Given this list of marker genes Dnajb11, Spag7, Trappc6a, Anxa7, Rpl8, Fnta, Sarnp, Snrpb2, Rbis, Cmas, Eci2, Pdcd5, Ssb, Ybx3, Ppp1r2, C1d, Lsm6 (NCBI Gene Id 78651), Psmb2, H2ax, Slc35b1, Rps21, Ncl, Rpl4, Polr1d, Sypl1, Arpc1a, Aprt, Nucb1, Ywhae, U2surp, Magt1, Calr, Fkbp2, Mrps26, Atp6v0d1, Eif3a, Naa50, Snrnp27, Ndufaf8, Rpn2, Rbm8a, Ndufs7, Pcna, Eif6, Dpy30, Spcs1, Ube2a, Stmp1, Dek, Cyb5a, Pih1d1, Akap9, Def6, Cisd1, Cnbp, Fh1, Cyc1, Eif3i, Cited2, Cdk12, Taf1d, Atp5mf, Mtch1, Frg1, Psenen, Pycard, Dazap1, Luc7l2, Asnsd1, Mtch2, Ptpa, Rps17, Me2, Rpl19, Slc25a4, Rnaseh2c, Tmed10, Sdha, Sf3b4, Ddost, Ywhaq, Polr2j, Snx5, Psmc5, Copb2, Srsf7, Psma3, Snrpa1, Ssr2, Rpl13a, Bin1, Tprg1l, Hmgn1, P4hb, Psmc2, Arl6ip4, Magoh, Ssrp1, Anapc5, Tsen34, Ppp1r11, Eny2, Rnf187, Atp5po, Sod1, Ndufb7, Cmtm7, Iqgap2, Chchd2, Gng12, Banf1, Cct3, Ndufb8, Tpi1 (NCBI Gene Id 21991), Ilf2, Phpt1, Mrpl28, Rps3a1, Hspe1, Ube2k, Rpsa, Hnrnpk, Cox7b, Ndufa13 (NADH:ubiquinone oxidoreductase subunit A13), Ndufs4, Eef1g, Eif4a3, Stk16, Sri, Ctsd, Rab4b, Atp5mj, Psmd14, Smdt1, Unc50, Polr2i, Atp6v1d (ATPase, H+ transporting, lysosomal V1 subunit D), Smc1a, Vdac2, Snf8, Hnrnpa3, Dynlrb1, Fubp1, Mrps24, Snhg8, Sin3b, Pin1, Ppm1m, Snx1, Pgk1, Esyt1, Gas5, Tmco1, Ifitm1, Dcun1d5, Snrpg, Med30 (NCBI Gene Id 70303, mediator complex subunit 30), Ndufv2, G3bp1, Srp19, Mrps12, Idh2, Hint1, Smc6, Mien1, Ilk, B230219D22Rik, Tmem167, Arpc5l, Gng2, Chtop, Ptbp1, Psmc3, Hsp90ab1, S100a10, Rtraf, Mrpl30 (mitochondrial ribosomal protein L30), Immt, Etfb, Supt4a, Ciao2b, U2af1, Rps18, Pcnp, Polr2c (NCBI Gene Id 20021), Twf2, Dohh, Rps8, Etf1 (NCBI Gene Id 52117), Jtb, Uqcrc2, Psmd6, Pdcd10, Hnrnpdl, Psmb3 (proteasome (prosome, macropain) subunit, beta type 3), Kcnq1ot1, Prdx6, Ahsa1, Sfr1, Tmem254, Slc3a2, Slbp, Rps26, Lta4h, Rbbp4, Ufc1, Rdx, Cct4, Pole4, Sar1b, Dnaja2, Ak2, Tmem165, Antkmt, Rab24, Lrrc59, Hp1bp3, Mrpl58, Edem2, Trappc2l, Cnih4, Psme1, Lat2, Anxa1, Khk, Erp44, Sod2, Fam133b, Mrps25, Smc4, Psma1, Rtcb, Sec13, Btf3l4, Nudcd3, Cox5b, Hspd1, Idh3g, Cks2, Ankrd13a (ankyrin repeat domain 13a), Ube3a, Cox8a, Atp5me, Mrpl52, Lage3, Nsmce1, Rpl7l1, Dctn3, Emc10, Csnk1a1, Cirbp, Rer1, Ogfrl1, Sumo1, Luc7l3, Mvb12a, Glipr1, Naa20, Psmb4, Rbm17, Nudt21 (nudix hydrolase 21), Psmb5, Vrk1, Tmem256, Ola1, Jchain, Thoc7, Rplp0, Glrx5, Swi5 (NCBI Gene Id 98849), Vmp1, Atp5f1b, Mif, Trappc6b, Naca, Cdc26, Ube2n, Pin4, Cuedc2, Rpl15, Chchd3, Dnajb6, Psma7, Cenpx, Ndufs2, Rpl7a, Cdc5l, Vdac3, Sdhc, Ebp, Dnajc19, Rpl36al, Hnrnpd, Ewsr1, Impdh2 (inosine monophosphate dehydrogenase 2), Rps25, Commd2, Ndufa12, Nars1 (asparaginyl-tRNA synthetase 1), Mdh2, Gm9320, Sdf4, Cisd2, Fundc2 (NCBI Gene Id 67391), Prdx3, Canx, Uba2, Eif3g, Osgep, Bin3 (NCBI Gene Id 80552), Park7, Srsf2, Nans, U2af2, Mlf2, Stmn1, Vars1, Ndufc2, Bcas2, Reep5, Anapc13, Taf10, Cox7a2, Commd7, Eif1ax (eukaryotic translation initiation factor 1A, X-linked), Sdf2l1, Lamtor5, Snu13, Pebp1, Casp8, Acadl, Cdk4, Atp5mc1, Hmg20b, AW112010, Cd47, Phb1 (NCBI Gene Id 18673), Rps6, Emg1, Rps20, Mrpl4, Cct8, Cma1, Rbm42, Cox5a, Rpl21, Dpm3, Ms4a6d, Tram1, Cdc123, Fbl, Gemin7, Psmg4, Ddx39b, Taf9, Cwc15, Tuba1b, Rpl31, Ndufa2, Lsm12, Rtf2, Smc3, Ppia, Bloc1s1, Bsg, Siva1, Wbp11 (WW domain binding protein 11), Rbm39, Exosc3 (NCBI Gene Id 66362), Sec61a1, Rab1a, Surf4, Ap2s1, Bzw1, Mrps36, Mtdh, Capg, Kdelr2, Cope, Oser1, Rbck1, Prpf4b, Pam16, Acp1, Atg3, Phf5a, Nubp2, Rab18, Rwdd1, Snrnp40, Commd4, Csnk2b, Arl6ip1, Caprin1, Mydgf, Uqcrq, Rbmxl1, Ik, Map2k3, Hmgb2, Saraf, Smim30, Tcp1, Atp5pd, H2bc4, Eif2s2, Acat1, Chrac1, Ccz1, Gorasp2, Cuta, Mff, Comt, Psmd4, Nt5c3 (NCBI Gene Id 76506), Lmo2, Bag1, Plekhj1 (NCBI Gene Id 78670), Churc1, Pigbos1, Selenoh, Ly6c2, Gpx4, Vps28, Mrpl15, Vps29, Sec22b, Dctpp1, Rpl3, Smim11, Idh3b, Nme1, St13, Ndufb2, Tex261, Rad23a, Ran, Txnl1, Cript, Rbm3 (RNA binding motif (RNP1, RRM) protein 3), Gps2, Leprotl1, Pgp, Eif4g1, Rsrc2, Eif4g2, Ift20, Ubxn1, Ube2r2, Mrps16, Vcf1, Yeats4, 1810009A15Rik, Hmgb1, Gnai3, Ndufs8, Glrx3, Thrap3, Hectd1, Pak1ip1, Pabpn1, Rsl24d1, Mrpl12, Ddx46, Atp5mk, Mrpl36, Polr1f, Cks1b (NCBI Gene Id 99474), Stub1, Psmd8, Aamp, Ubl7, Prdx4, Rps10, Grpel1, S100a8, Mrpl42, Psmd3, Gna13, Mrpl33, Dctn2, Prelid1, Pfdn2, Cnih1, Bax, Mrpl57, Emd, Mcts1, Psmd13, Vdac1 (NCBI Gene Id 22333), Gtf3a, Stt3b, Ghitm (NCBI Gene Id 66092), Smim7, Rheb, Ebna1bp2, Nap1l4, Tmem258, Uqcrb, Atp5pf, Tax1bp1, Polr3k, Eloc, Hnrnpm, Smap1, Sf3b5, Mat2a, Dph3, Sdhd, Baz1b, Trmt112, Ndufs6, Psmd7, Pnp, Mrpl17, Ccni, Coa3, Pcbp2, Ccnd3, Bnip2, Cfdp1, Ethe1, Mrps14, Mrpl34, Cers2, Lgals1, Grina, Rsl1d1, Yy1, Tuba4a, Nfu1, Bloc1s2, Slpi, Tbcb, Commd3, Dut, Ddx21, Cdkn2d, Hpf1, Polr2k, Mtx2, Ppib, Sms, Mrps18c, Polr2l, Rgs18, Uchl5, Rp9, Ndufv3, Arpp19, Rpl29 (ribosomal protein L29), Mlec, Rbm25, Rps16, Erh, Rab5if, Uqcr10, Cops9, Rpl12, Chchd1, Ube2i, Arid1a, Slc25a11, Pkig, Dap, Wdr83os, Fkbp3, Ctcf, Tmem208, Psmb6, Tap1, Mpc2, Aco2, N4bp2l2, Glrx, Pet100, Fkbp8, Tm9sf3, Anp32b (NCBI Gene Id 67628), Pgls, Lsm7 (NCBI Gene Id 68716), Lsm5, Erdr1, Cycs, Cox7c (cytochrome c oxidase subunit 7C), Serpinb1a, Timm23, Cbx3 (NCBI Gene Id 12417), Ntan1, Rplp2 (NCBI Gene Id 67186), Pdap1, Rbfa, Tmed9, Eif3l, Bak1, Spcs2, Drg1, Rnh1, Bbip1, Stx7, Rack1, Srsf9, Vrk3, Purb, Apobec3, Eif5a, Skap2, Elf1, Cebpd (CCAAT/enhancer binding protein delta), Rpl31-ps12, Snrpe, H2ac23, Znhit1, Anxa11, Snrpd1, Trappc5, Hint2, Gtf2h5, Rad23b, Ergic3, Ndufb11, Cdc37, Lamtor3, Sumo2, Ssu72, Ndufb4, Prdx2, Rps2 (NCBI Gene Id 16898), Txn1, Mrps17, Elob (elongin B), Atp6ap2, Rbbp7, Cct5, Rpl32, Mbnl1, Psmc1, Ssbp4, Lman2, Etfa, Snhg3, Emc8, Ncbp2as2, Zfp207, Mgat2, Slc25a3, Psma4, Gpi1 (NCBI Gene Id 676974), Dync1i2, Tra2b, Lsm3, Pfdn6, Srrm2, Snrpf, Ndufb10, Fermt3, Tmem234, Ndufa4, Smarca5, Ssr3, Micos10, Aurkaip1, Vbp1, Selenot, Trappc4, Prpf38b, Mrpl18, Rpl39, Eif4b, Ube2f, Atp6v1e1, Tcf25 (transcription factor 25 (basic helix-loop-helix)), Mrpl11, Hdlbp, Psma2, Lsm14a, Ssr4, Mrpl14, Rpa3, Hprt1, Pdia3, Snrpd2, Snrpd3, Dnajc8, Cd24a, Strap, Sec61g, Sra1, Tceal9, Tmed3, Sfpq, Nudc, Brd7, Psmb9, Cops6, Nfe2, Atp5pb, Nme2, Btf3, Selenos, Pdia4, Yif1b, Gars1, Pdrg1, Plp2, Emc7, Dpm1, Serbp1, Txn2, F13a1, Ociad1, Cox20, Ndufs3, Cib1, Slirp, Atp5f1a, Acaa1a, Pa2g4, Ube2l3, Timm13, Rpl6, Rtn3, Sec61b, Npm3, Lsm4, Mtln, Slc38a2, Eprs1, Ccnl1, Sell, Actl6a, Eif3c, Eef1b2, Bri3bp, Eif5b, Eif4a1, Rpl14, Snrpa, Mrpl23, Polr2m, Utp3, Naa38, Hdgf, Lsm2, Bud31 (NCBI Gene Id 97220), Ppp1cc, Maz, Pmf1, Ssna1, Rrbp1, Ctbp1, Plgrkt, Srsf3, Tial1, Rpl22l1, Naa10, Atf4, Tsn, Ndufb5, Psmc6, Abcf1, Rrp1, Fam111a, Mrpl32, Rfc2, Rnf10, Mrpl24, Lrpap1, Tspo, Psmb7, Lmnb1, Micos13 (NCBI Gene Id 319512), Commd1, G3bp2, Ndufv1, Ywhah, Mrps33, Mrpl20, Llph, Eif3m, Ciao2a, Trappc1, Tsg101, Tomm20, Psmd2, Mt1, Hspa5, Ramp1, Tomm22, Trp53, Zfas1, Tmem33, Atf1, Ppig, Use1, Ndufa8, Bola2 (bolA family member 2), Rpp21, H1f2, Rps15a, Tnfaip8, Ostc, Vps35, Ap3s1, Psma5, Mpc1, Txndc17, Hypk, Srrm1, Elof1, Fkbp4, Snrnp70, Map2k2, Tpr, Tubb4b, Tubb5, Pcbp1, Rpia, Mir703, Hnrnpa2b1, Rgs19, Tcof1, Tuba1a (NCBI Gene Id 22142), Eef1d, Ndufc1, Tm2d2, Creg1, Was, Hmgn2, Glo1, Mrpl21, Dnajc15, Psmb1, Prpf19, Pdcl3, Sptssa, Smarce1, Tbca, Tmem14c, Rps12, Phb2, Mrpl54, Fgfr1op2, Suds3, Dnajc9, S100a9, Dnajc3, Esd, Acbd6, Nsmce4a, Tmem147, Cstb, Top1, Napa, Eif2a, Eif4e2, Mapre1, Alyref, Slfnlnc, H2az2, C1qbp, Hsd17b10, Mrpl35, Krcc1, Gspt1 (NCBI Gene Id 98017), Hspa4, Snrpc, Cbfb, Rsrp1, Anp32e, F10, Mrpl27, Sec11c, Bscl2, Hsp90aa1, Sys1, Pfdn4, Cct7, Ndufb6 (NCBI Gene Id 277815), Csrp1, Zranb2, Rnf7, Clns1a, Csnk2a1, Uqcc2, Nkg7, Paics, Romo1, Pdia6, Celf2, Sf3b6, Nrdc, Rpl22, Ddrgk1, Usp1, Cd63, Gapdh, Fabp5, Ccdc115, Pcmt1, Polr1h, Bub3, Timm8b, Mapkapk3, Bad, Mplkip, Sf3b2, Mdh1, 1110004F10Rik, Nipbl, Pnn, Rpl41, Sec11a, Guk1, Zeb2, Dstn, Son (Son DNA binding protein), Ptges3, Ankrd11, Atrx, Echs1, Vcp, Nop58, Sf3b1, Atp5mc2, Cmpk1, Gadd45gip1, Cox6c, Akirin2, Srsf6, Sdhb, Cct2, Tmem126a, Sltm, Atp5f1d, Uqcr11, Ap2m1, Rex1bd, H2az1, Mrps21, Krtcap2, Ndufa10, Rpl5, Igbp1, Npm1, Pim1, Nol7, Prrc2c, Nrm, Xrn2, Arf4, Trir, Set, Actr10, Metap2, Rexo2, Rad21, Aimp1, Vti1b, Nhp2, Hnrnpr, Ranbp1, Uqcc3, Dnajc2, Hnrnpab, Hnrnph1, Chmp2a, Gusb, Ptma, Rps5, Gm15421, Ppp2r1a, Sars1, Mrpl43, Tmbim4, Srsf1, Eif4h, Zc3h15, Nelfb, Pdcd6, Timm17b, Mkks, Ndufa11, E2f4, Ube2v1, Prpf40a, Srsf11, Ssbp1, Mcrip1, Sp3, Prmt1, Rpl36a, Rpn1, Atp5if1, Psma6, Gtf2a2, Chd4, Nsa2, Cdk9, Macroh2a1, Nubp1, Trim28, Acin1, Dtymk, Ramac, Rpl10a, Ndufb3, Pfdn1, Eif1b, Mrps15, 0610010K14Rik, Kif5b, Exosc5, Vamp8, Srp9 (signal recognition particle 9), Arf5, Nucks1, Mrpl40, Emc6, Ybx1, Fmc1, Higd1a, Samm50, Spg21, Atp5mc3, Syncrip, Ppm1g, Psmc4, Tecr, Psmd12, Tmem30a, Ifi27, Eif3d, Pgam1, Manf, Tomm5 (translocase of outer mitochondrial membrane 5), Cetn3, Ckap4, Cfp, Mrpl51, Eif4e (NCBI Gene Id 668879), Rplp1, Polr2f, Snhg6, Txnl4a, Pts, Anapc11, Atraid, Ssr1, Cacybp, Ndufab1, Rpl35, Tmpo, Sec62, Hdac1, Ech1, Ndufa5, Cnpy2, Babam1, Ldha, Imp3, Paip2, Suclg1, Erp29, Eif2s1, Med8, Zmat2, Pafah1b1, Adh5, Fus, Ndufb9, Ndufa7, Pigt, Lamtor4, Zcchc17, Cox16, Lamtor1, Adss1, Mrps23, Rps3, Lbr, Denr, Hp, Rpl23, Got2, Sumo3, Rps27l, Uqcrfs1, Rab2a, Morf4l2, Tmem176a, Uqcrc1, Nap1l1, Hnrnpc, Ccdc124, Nxt1, Stoml2 (NCBI Gene Id 66592), Pcbd2, Rtf1, Rpl28, Ccl5, Rab32, Calm3, Cs, Edf1, Ube2s, Eif3b, 1810037I17Rik, Bola3 (NCBI Gene Id 78653), Baz1a, Ubxn4, D8Ertd738e, Snhg1, Cebpz, here is a description of the gene set: Mouse Gene Set: TABULA_MURIS_SENIS_SPLEEN_PROERYTHROBLAST_AGEING from publication Tabula Muris Consortium (PMID 32669714) species: Mus musculus